Given this list of marker genes CIITA, RFXANK, RFXAP, JAK3, RFX5, here is a description of the gene set: Acute otitis media Human Gene Set: HP_ACUTE_OTITIS_MEDIA studied in species Homo sapiens Acute otitis media is a short and generally painful infection of the middle ear.